The following is a description of a gene set: part of: Metabolic disorders of biological oxidation enzymes Reactome Pathway: Defective TBXAS1 causes GHDD studied in species Homo sapiens Thromboxane-A synthase (TBXAS1), an enzyme of the arachidonic acid cascade, produces thromboxane A2 (TXA2) from prostaglandin H2 (PGH2). Together with prostacyclin (PGI2), TXA2 plays a key role in the maintenance of haemostasis. It is also a constrictor of vascular and respiratory smooth muscle and implicated in the induction of osteoclast differentiation and activation. Defects in TBXAS1 can cause Ghosal hematodiaphyseal dysplasia (GHDD; MIM:231095), a rare autosomal recessive disorder characterised by increased bone density with predominant diaphyseal involvement and aregenerative anemia, a bone marrow failure where functional marrow cells are regenerated slowly or not at all., and this is the list of marker genes: TBXAS1